The following is a description of a gene set: from publication Yevshin I, Sharipov R, Kolmykov S, Kondrakhin Y, Kolpakov F (PMID 30445619) species: Homo sapiens Human Gene Set: ZNF589_TARGET_GENES Genes containing one or more binding sites for (ZNF589) in their promoter regions (TSS -1000,+100 bp) as identified by GTRD version 20.06 ChIP-seq harmonization., and this is the list of marker genes: SESN2, AVPI1, ACRBP, TMBIM1, DYNC1I2, LEPROTL1, LINC00607, RABGAP1L, AMIGO1, LINC01732, TMEM268, AP3M2, UBE3D, CDK5RAP2, ZNF585A, ENSG00000232884, ZC3H12A, ENSG00000249713, RFC1, LTF, ZNF649, ENKUR, CDK20, LCOR, H2AC12, KCNAB1, TRPC4AP, POLDIP3, PPP4R1L, AGK-DT, MAPK8IP1, CFAP99, APBB1, ATF7IP2, HLTF, AP2S1, TRIM59-IFT80, RPL36AP7, IFT140, RNA5SP96, NSD1, CTU2, SEC24C (NCBI Gene Id 9632), ZNF341-AS1, SYNRG, ZNF451, ICAM2, PRKCA, UBE2E3, ENSG00000254718, AKT1S1, TAL1, UBE2V1P4 (UBE2V1 pseudogene 4), KDM7A-DT (KDM7A divergent transcript), FGGY, ACTG1, CHMP3, RERE, PRR5, LASP1, LINC01629, CCDC162P, CASP2, CCDC88A, EPB42, ST7-OT4, SLC35F6, CCDC124, RN7SKP168, SAMD9L, LINC01287, SDE2, LAMP1 (NCBI Gene Id 3916), CASS4, MATN1-AS1, HM13, FCRLB, ZNF815P, HMBOX1, LARP1B, RNU6-169P, MFAP3L, GGACT, ZBTB14, RAB5IF, STRIP1, CBFA2T3, AGER, GCN1, MIR193A, LINC02863, DNHD1, KRBA1, ACTB, ZNF280D, PNPO, H3-3B (H3.3 histone B), AHI1, MYCL, BRD2, ANO7, RNU6-1216P, GBA1, SRRM2, OTUD7A, NDUFA4, TCERG1, GNB1, NUDCD1, SPNS1, TBC1D17, ADAM9, SLC25A11, STX18-AS1, TBL1X, SCG3, HTATSF1P2, DPP9, MKKS, OPLAH, NUMA1, TANC1, CHD4, PPT1, USP6NL, MRPS30-DT, CALB1, MAPK13, TNFAIP1, ACSF3, CARMIL2, DHRSX, SLC48A1, CLCN7, CHCHD2P1, KCTD10, LINC02695, SELPLG, WDR36, ALG1L13P, HMBS, CLPX, IFRD2 (NCBI Gene Id 7866), ANPEP, WTAP, MYL6, UBR3, MIR7-3HG, SHLD1, PTPRS (NCBI Gene Id 5802), TPBGL-AS1, ST3GAL2, HMGN2P34, IL23A, USP9X, CSMD1, FAM111A, TSNAXIP1, PHF12, MELK, MRPS30, TMEM11-DT, C6orf89, HIF1A, MYL6B-AS1, TRIM29, RAB7A, SCARNA2 (NCBI Gene Id 677766), LYSMD1 (NCBI Gene Id 388695), RIN3, ANK3, PLAU, ADAM15, H1-2, UTP11, SULT2B1, PRR13, ENY2, MXD1, BMAL1, NRXN3, RN7SKP192, AKR1E2, SEPTIN7P9, BCAT1, TEDC1, ODAD3, SMPD4P1, GPR158, ANKRD65, CLSTN1 (NCBI Gene Id 22883), CHEK1, MAZ, ENSG00000235978, TMEM273, PRR11, PPP5D1P, PTBP1, CDKL3, COG3, CDYL, CSTF3, KRTAP2-4, PUM1, KLF1, KPNB1, LINC00958, HMGXB3, TLCD2, EPC1, PEX16, MFAP1, MSRB3-AS1, CENPA, ENSG00000253986, PTPN22, MUS81 (MUS81 structure-specific endonuclease subunit), RNVU1-15, C19orf38 (chromosome 19 open reading frame 38), MAN2A2, FHL2, TMA7B, RALGDS, CADM3-AS1, TM4SF19-DYNLT2B, ADGRD1, PPP1R12C, SNHG5, TULP2, SREBF1, PLEKHF2, MTMR4, MR1, ASAP3, WSB1, PLSCR2, TRIM59, FOXK2, ENSG00000227706, LNCTSI, CAPG, SH3TC2-DT, TBC1D4, MUC20-OT1, LINC00887, SH3GL1, LNCATV, TRAJ23, SPG11, WDSUB1 (NCBI Gene Id 151525), RNU12, TTC41P, OLA1, SCG2, IKBKB-DT, PTPRN2, SFI1, C11orf21, TMEM139-AS1, LDLR, YPEL4 (yippee like 4), SELENOH, RN7SL371P, DGCR8, MIR7-3, TOLLIP-DT, RNVU1-4, TRIB3, TMED1, CLP1, FGD6, SCUBE1-AS1, IL1R1, SCRIB, ZEB2-AS1, PFKFB2, GSK3B-DT, FARP2, MPV17L2, NDUFB5, ATG9A, PTK2, LINC02178, SLC22A18, RNF166, SLC7A5P1, GYPA, SLX4IP, TBC1D20, RNU5F-1, IFI27, TMEM11, PANK4, VOPP1-DT, MAG (myelin associated glycoprotein), UBE2D2, THUMPD2, NAGLU, PTPRN, PRSS2, TM2D2, DHX40, FRG1-DT, S100Z, OSBP2, SAP30-DT, ESD, MIR3681HG, RRP1B, SP2-AS1, POLR1H, DDX3ILA1, STAP2, IGF1R, ZSCAN31, FAM83A-AS2, RNF167, MARCHF4, SPI1, CTSB, P4HB, CASZ1, RNVU1-34, PXMP4, ARAF, SCMH1, RUNX1T1, LEMD2, SCAMP5, MARCHF2, MAGOHB, CALM3, NOSIP, IQGAP2, ZFYVE28, RNU1-108P, ZNF77, MRFAP1, ANKS6, NCOA2, PRKD1, SLC4A2, AQP8, USP36, IFT20, PHF21A, MAD1L1, CNPY3, USP28, C12orf76, COX16, ZNF484, CCT7, GSK3B (glycogen synthase kinase 3 beta), ABCG1, UBE2E3-DT, AKAP13, BARHL1, XPO6, H2BC12, TNFRSF10A, INTS9, TASOR2, SLC25A45, CP, TYK2, CPNE2, RELL1, ST7, BABAM1, LINC02842, COX6CP5, PPM1A, SLK, RIPOR3, TOR1AIP1, SMG1P3, LINC02252, ADD1, LUCAT1, TSC22D1, WBP1, MYO5B, ARMH4, NFX1, EHD1, VOPP1, ACSL6, PGP, PPRC1, PKN1, CA1, DNAJB2, MLLT10, RAB30-DT, LUC7L3, S100A2, CLEC16A, MIR584, RPL31, AKR1A1, RAD51C, OAZ1, ZNF350, LRRC8B, LINC02985, CARD8-AS1, RANBP2, FCHSD2, HSF2BP, RPL24, RNA5SP60, BCL7C, LINC02928, EPC1-AS1, UBALD2, FAXDC2, GLRA1, SPINK4, TMEM116, ECH1, SETD4 (NCBI Gene Id 54093), MASP1, XKR9, ACIN1, TBCCD1, ZFYVE1 (NCBI Gene Id 57694), UNK, GNG4, UBE2E2-DT, FEM1A, RYBP, DNAJB11, AP3B2, ARF4, ARHGEF12, GAS8, SCNM1, SKA2, TSC1, RNF227, RANBP10, ALKBH3-AS1, SRGAP2, CHMP4B, GZF1, RHOA (ras homolog family member A), TPH2, SAP30, SKIL, HERC1, DESI1, B3GNTL1, UBE2O, ZBTB8OS, HTR5A, CLPB, ALDH1A2, EHBP1L1, ENSG00000226706, KRT13, SSH1, MPND, UBA5 (ubiquitin like modifier activating enzyme 5), SIGLEC27P, IRF2BP2, TNFRSF10A-DT, DNAJC5, FRG1, KHSRP, MIR4729, ZEB2, PKD1L2, CDCA3, FBXO15, ALG6, RNU6-218P, PRKCE, RUNDC3A-AS1, ATP5F1A, LINC01275, H4C5, RUNDC3A (NCBI Gene Id 10900), MIR4766, TM4SF19, ZNF175, AGK, FAM83A, SLC7A5P2, CCDC137P1, CFL1, CYB5R4, RABGAP1L-DT, PSMA3-AS1, ADGRB3-DT, NPEPPS, HP1BP3, CAMKK2, NOS3, METTL3 (NCBI Gene Id 95719), LINC02772, PI16, LYN, MILR1, CNOT1 (CCR4-NOT transcription complex subunit 1), LINC01686, VILL, MIR223HG, VPS29, LIMA1, SMARCA4, DNAAF5, STC2, STK25, C1orf74, TMEM167B, NOP53, CACTIN, SRD5A3-AS1, SYP, CRCP, MDH1, SGTA, JSRP1, CSTF3-DT, SUMO2 (small ubiquitin like modifier 2), DNAJB1, MRGBP, ANKZF1, SNRNP35, PPM1E, OARD1, RNU5E-4P, SCRT1, TSPAN31, B3GAT3P1, USP31, PRKCSH, BSG, HS1BP3-IT1, RAD9B, WDPCP, NFIX, UBE3C, TIPRL, CXCL16, KCNK1, ABCA17P, VEZT, BUB3 (NCBI Gene Id 9184), LINC02777, SLC39A3, ENSG00000239096, RNU11, RAB30, CYP2W1, ACP5, NFATC3, SLC9A3-AS1, KPNB1-DT, EOGT, GAB2, ARRDC2, FAM72A, PCMTD2, PPP1R15A, FLYWCH1, MGRN1, IFI16, MEF2C-AS1 (NCBI Gene Id 105379072), CHD7, CEP131 (centrosomal protein 131), HSP90B1, NFYA, NFASC, SLC7A5, TRIP6, TMEM181, SLMAP, STX18, LINC02613, MIR1205, KIFC3, EIF3B, CFL1P8, ASIC4, TOLLIP, SND1, BRWD1, ANK1, NEUROD4, ABCA10, MEF2C, RNU5E-1, LYPLA1, RBL1, STAT5B, DMAC2L, FNBP1, NSUN5, SUMO3, LACTB2, NUMBL, UBE2E2, SUPV3L1, PTBP3, KICS2, MIR3143, TBX6, ACCS, SLC25A6, RPF1, MIR4441, NADK2, LINC01257, TEX14 (testis expressed 14, intercellular bridge forming factor), ALDH5A1, RHOG, RPL10P7, CARINH, BOD1, PCK2, SIAH1, SLC9A3-OT1, ENSG00000260288, MLXIP, LSM10, ABCA3, BANCR (BRAF-activated non-protein coding RNA), SNX12, ENSG00000266401, AP2A2, CNOT10 (NCBI Gene Id 25904), COSMOC, MEGF11, NFE2, ADGRB3, CRAMP1, ACBD5, ZNF48, GET4, PPP6R1, CD22, NUCB2, PAFAH2, LINC01215, FADS1, CAMTA1, ERP29, FASN, BTG3-AS1, PCBP1-AS1, GRAP2, TCTA, GYPB, MIR548AW, CCDC137, ORMDL3, FAAP20, PLA2G6 (phospholipase A2 group VI), CXXC1, CDK5, TMBIM6, DTNB, TSSK3, COPS6, NPEPPSP1 (NCBI Gene Id 440434), SNHG32, EXPH5, SNAP25-AS1, TIMM21, ZNF331, SCAND3, SLC14A1, RNU6-299P, KDM3A, BIN1, DCP1A, TK2, NFYB, MIER1, ENSG00000263280, CMTM3, GNB1-DT, KDM7A, IRF9, RDUR, RPL36P10, LINC03023, GFI1B, RPS26, LINC02093, RBBP4, PPOX, RPL29P20, GTF2IRD1, PRMT3, MIR130AHG, SNORD48, VWA7, POLR1HASP, LINC02683, YJU2 (YJU2 splicing factor homolog), USP20 (NCBI Gene Id 10868), TTC39A, LRRC41, CAMTA1-DT, CHCHD2P6, ARID4A